Given this list of marker genes ARHGEF9, TUBB3, TRMT10C, PPFIBP1, ADGRG1, DYNC1H1, AHI1, here is a description of the gene set: Human Gene Set: HP_FRONTAL_POLYMICROGYRIA Frontal polymicrogyria A type of polymicrogyria with a gradient of severity (anterior more severe than posterior) extending from frontal poles posteriorly to precentral gyrus and inferiorly to frontal operculum. studied in species Homo sapiens